Given this list of marker genes ZEB2 (zinc finger E-box binding homeobox 2), TUBB3, PI4K2A, RERE, MACF1, here is a description of the gene set: Underdevelopment of the anterior commissure. studied in species Homo sapiens Human Gene Set: HP_HYPOPLASTIC_ANTERIOR_COMMISSURE Hypoplastic anterior commissure